Given this list of marker genes CD36, TLR2, LILRB3, NLGN1, IDE (NCBI Gene Id 3416), FZD4, GRIN1, GSAP, HSPG2, BACE1, ARMCX5-GPRASP2 (ARMCX5-GPRASP2 readthrough), NGFR, PRNP, FPR2, C1QA, APBA1, PGRMC1, KIR3DL1, COL25A1, LDLR, APOA1, ACHE, ITGA2, GPRASP2, LILRB1, APBA3, PFDN5, TLR4, GRIA4, LDLRAP1, CRYAB, CST3, LDLRAD3, LILRB2, LRP1, CACNA1A, FZD5, BCHE, ADRB2, MAPK8IP2, APOE, GRIN2A, TREM2, INSR, APBB2, CALCR (NCBI Gene Id 799), FBXO2, SORL1, FCGR2B, CHRNA7, ITGB2 (integrin subunit beta 2), RAMP3, TM2D1, LRP8, DLGAP3, CLSTN1, EPHB2 (EPH receptor B2), ITM2C, TGFB2, GRIA2, EPHA4, IAPP, SCARB1, CLU, MARCO, ITM2B, ITM2A, PFDN4, ITGAM, PICALM (phosphatidylinositol binding clathrin assembly protein), ATP1A3, TLR6, GRIA3, LRPAP1, PFDN6, MSR1, VBP1 (VHL binding protein 1), CACNA1B, APBA2, PFDN1, APBB3, FZD6, GRIN2B, GRIA1, CD74, AGER, APBB1, PFDN2 (NCBI Gene Id 5202), here is a description of the gene set: Binding to an amyloid-beta peptide/protein. species: Homo sapiens Human Gene Set: GOMF_AMYLOID_BETA_BINDING